The following is a description of a gene set: studied in species Homo sapiens from publication Peltier DC, Simms A, Farmer JR, Miller DJ (PMID 20483728) Genes down-regulated in neuron cell line treated with interferon alpha for 6h: immature versus mature. Human Gene Set: GSE16450_IMMATURE_VS_MATURE_NEURON_CELL_LINE_6H_IFNA_STIM_DN Human neuronal differentiation alters responsiveness to innate immune stimuli and virus infections. We used microarrays to examine the transcriptional responses of the human BE(2)-C neuroblastoma cell line to retinoic acid-induced differentiation and type I IFN stimulation., and this is the list of marker genes: GLRX, GC, EFNA4, APEH (acylaminoacyl-peptide hydrolase), HPS6, PLBD2, CTXN2, IMPDH1, ALPL, TMEM121B, NTN1 (NCBI Gene Id 9423), EMILIN3, GABRQ, VEGFA, GPR88, COG6, SOWAHA, RNF32, NKX2-4, ASB4, ZDHHC8, DTNA, BPIFC, HSFY2, TMEM161A, MED16, CLUH, GDPD3, DMBT1, UBAC2, KCNH2, PRDM1, DDX3Y, B3GNT7, ZBTB7B, RAB13, CARMIL2, BMAL2, EPB41L4B, MAPK8IP1, TRAIP, SUN3, SLC4A3, LMF2, CDK11B, STOML2, CREB5, ZPBP2, PTPRE, FKBPL, HAAO, SEC14L2, MYO16, MT1E, PRDM9, RPS6KB2, SMPD5, SMCO1, EVC2, CD36, HIRA, C19orf44, ANKRD9, HEPACAM2, NQO1, DCAKD, RNH1, RYR1, RPUSD1, PCDH9, PHOX2A (paired like homeobox 2A), GALNT6, DAO (D-amino acid oxidase), MTA3, UTY, IL4R, ADTRP, XKR6, SLC31A1, TENM1, ALDH5A1, HAGHL, MX1 (MX dynamin like GTPase 1), GLB1L, NIPAL1, LAMC1, CNOT10, VSTM2L, GDF10, MS4A10, RCC1, POLR3GL, ITGA2B, RBCK1, RGS14, GRPR, MOS, GSX2, LIPN, RAB8A, C15orf39, IL3RA, PNPLA1, SGK1, CMTR1, PITPNM1 (NCBI Gene Id 9600), ZNF580, KCNG4, MASP2, LIMK2, PLAUR, ZNF43, ARHGAP9 (Rho GTPase activating protein 9), TXNDC5, NOL12, XBP1, ERICH2, ARPC1B, COL4A2, FBXO7, COL11A2, TYRO3, PPP1R3B, SLIT1, FMNL3, B3GNT2, PAX4, DPCD, SLC12A9, FZD7, RXFP1, ART5, CHRNA5, SLITRK3, HYAL3, TMEM231, TRPV2, F2RL3, PLEKHH2, UMODL1, GAPDHS, SYT12, IFITM5, TAFA2, IGHM, PSEN2, SIDT1, BOP1 (BOP1 ribosomal biogenesis factor), DCAF15, LRAT, CCN5, CA5B, NSUN5, ALDH16A1, ZNF704, KLF7, BRPF1 (NCBI Gene Id 7862), HCN2, GLYAT, RCSD1, GORASP1, ITPR3, ADCK5, KRT33A, KCNF1, IRF4, ADH7, GPAA1, ACRV1, FAM117A, LDHC, UNC5A, GM2A, LINC01973, BMP2, CYB5RL, PARVG, RP1L1, GNL1, CCR1, E2F2, RAC3, ITGA8, SLC7A4, TMOD2, KDM5D (lysine demethylase 5D), HIP1, TLN1, SLC16A9, EIPR1, SLC18A2, COG2, CSF3, ISG20, SNAI3-AS1, LRRN1, ZBTB12, FBLN2, BZW2, MTF2